Given this list of marker genes SELP, CLU, SERPINF2, SERPINE2, TGFB3, KNG1, APP (NCBI Gene Id 351), F5, HRG, FN1, IGF2, SPARC, PLG, VAMP7, FERMT3, FGG (fibrinogen gamma chain), STXBP1, VTI1B, CD109, A2M, THBS2, TIMP1, CD36, AHSG (NCBI Gene Id 780898), ORM2, PPBP, GAS6, SRGN, VEGFD, SERPINA3, VWF, PCYOX1L, TGFB1, F8, ACTN4, TMSB4X, STXBP3, CFD, SYTL4, ACTN1, TREML1, SERPING1, ACTN2, IGF1, SERPINA5, TMX3, APLP2, PECAM1, GTPBP2, LY6G6F, PCDH7, LHFPL2, ISLR, TOR4A (torsin family 4 member A), VEGFC, SERPINE1, SCCPDH, APOOL, LEFTY2, SNCA, TGFB2, F13A1, EGF, CYB5R1, VEGFB, CYRIB, OLA1, NHLRC2, MAGED2, VEGFA, A1BG, PHACTR2, FGA, SERPINA1, ITGB3, PF4, FGB, MMRN1, PDGFA, VPS33B, ALDOA, QSOX1, TEX264, ORM1 (NCBI Gene Id 5004), PROS1, HGF, PDGFB, ALB (NCBI Gene Id 29004), CD9, THBS1, ITGA2B, here is a description of the gene set: species: Homo sapiens Human Gene Set: GOCC_PLATELET_ALPHA_GRANULE A secretory organelle found in blood platelets, which is unique in that it exhibits further compartmentalization and acquires its protein content via two distinct mechanisms: (1) biosynthesis predominantly at the megakaryocyte (MK) level (with some vestigial platelet synthesis) (e.g. platelet factor 4) and (2) endocytosis and pinocytosis at both the MK and circulating platelet levels (e.g. fibrinogen (Fg) and IgG).